The following is a description of a gene set: studied in species Homo sapiens Any process that stops, prevents, or reduces the frequency, rate or extent of transcription elongation, the extension of an RNA molecule after transcription initiation and promoter clearance by the addition of ribonucleotides catalyzed by a DNA-dependent RNA polymerase. Human Gene Set: GOBP_NEGATIVE_REGULATION_OF_DNA_TEMPLATED_TRANSCRIPTION_ELONGATION, and this is the list of marker genes: NELFA, SUPT4H1, NELFE, RECQL5, LARP7, PPP1CA, WDR82, EAPP (E2F associated phosphoprotein), PPP1R10, SUPT5H, SHH, SIRT6, PARP1, AXIN1, VHL, ZC3H4, NELFCD, RNF168, TCERG1, RNF8, EZH2, NELFB, HNRNPU, RN7SK, HEXIM1